Given this list of marker genes TEX14, PRMT2, KANK2, ATM, MIR133B, E2F7, WEE1, PLK3, CTDSPL, MAD1L1, KNL1, TICRR, SDE2, TPR, CDC20, XRCC3, BABAM2 (BRISC and BRCA1 A complex member 2), INCENP, GIGYF2, GPR132, SPC25, EZH2 (NCBI Gene Id 392834), FOXO4, CCND1 (cyclin D1), MIR29C, SKA1, MRNIP, RBBP8, NAE1, DLG1, TRIAP1, FAM107A, RGCC, FBXO7, MIR16-1, MIR137, CHEK1, BTN2A2, GFI1B, MUC1, ATR, MIR30C2, TRIP13, INIP, MIR195, IK, CDK2 (cyclin dependent kinase 2), CDK1, MIR29A, ZFP36L1, USP44, RBL1, KLF4, RPA2, RINT1, UIMC1, FZR1, GPNMB, ZWILCH, CDKN2D, TOPBP1 (NCBI Gene Id 11073), ZW10, TAOK1, TAOK3, HEXIM2, HUS1B, ZNF655, AVEN (apoptosis and caspase activation inhibitor), BABAM1, CTDSP1, ZFYVE19, MIR15A, DACT1, CENPF, CDC14B, ACVR1, PLK1, ZWINT, SLFN11, CDC73, MIR26A1, MBTPS2, MIR133A1, TP53, HUS1, RFWD3, NABP2, DUSP1, ZNF207 (NCBI Gene Id 7756), PRAP1, PKMYT1, CHFR, MAD2L1, CDC6, RAD21, GEN1 (NCBI Gene Id 348654), CHMP4C, RB1, SPC24, PABIR1, PTEN, PRP4K, CDCA8, BLM, SKA3, BRCA1, STK35, PSMG2, RFPL1, CDK2AP2, FHL1, INTS3, JADE1, GTPBP4, VPS4A, SPDL1, BIRC5, WAC, BARD1, DYNC1LI1, CLSPN, BUB1, MIIP, PRKDC, RPS27L, CDKN1A, BRD7, NBN, FBXO5, CDK5RAP2, ZC3H12D, INHBA (NCBI Gene Id 3624), FBXO31, BUB3, CDK5RAP3, CRLF3, PINX1, APC, SYF2, ETAA1 (ETAA1 activator of ATR kinase), BRSK1, NABP1, TRIM39, HASPIN, NUF2, DGKZ, CCNB1, AURKB, DCUN1D3, MBTPS1, IER3, CTDSP2, RAD17, ANAPC15 (NCBI Gene Id 25906), ABRAXAS1, MIR29B1, MRE11, PDIK1L, CACNB4, CDKN2B (NCBI Gene Id 1030), MIR892B, MIR19B1, FOXN3, CCL2, BCL2, TREX1, DONSON, LCMT1, KLHL22, ZNF830 (NCBI Gene Id 91603), MIR451A, RAD50, MIR193A, BUB1B, TAOK2, MIR362, MIR15B, MYO16, MIR638, MAD2L2, RBL2, DTL, MAD2L1BP, KNTC1, NOP53, TPRA1, NDC80, PKD2, TFDP3, BRCC3, ZFP36L2, ORC1, TTK, here is a description of the gene set: Any process that stops, prevents or reduces the frequency, rate or extent of mitotic cell cycle phase transition. Human Gene Set: GOBP_NEGATIVE_REGULATION_OF_MITOTIC_CELL_CYCLE_PHASE_TRANSITION studied in species Homo sapiens